Given this list of marker genes ST6GALNAC2 (NCBI Gene Id 6488), DLK1, MCUB, IGFBP4, GABRP, GNG2, DLK2, EOGT, PLXDC2, FRZB, CEP55 (centrosomal protein 55), ABCA13, PFKP, NAAA, STXBP6, FST (NCBI Gene Id 10468), GXYLT2, SOSTDC1, MTBP, GABRG3, NTN1, PRKAR2B, DUSP5, LRP4, HLA-DPB1, KCNMB4, KLK10, AEBP1, MCC, FGFR1, SHISA2, LTB, EYA2, CXCL2, ROBO2, MYB, SLIT3, COL5A1, DKK3, LAYN, DDX60 (NCBI Gene Id 55601), LHFPL2, NTRK2, CCL2, DAPL1, CAVIN1, KLF2, MT1E, SH3BP1, DGKA, CD40, ITGA9, FERMT1, STRA6, PHLDA1, CSTA (cystatin A), ISL1, ABCG1, PLPP2, ACTA2, TMEM158, GNG12, APOD, PRLR, RCBTB2, RELL2, PART1, STK38L, BCL2A1, SLC1A1, RAC2, CFH, NDE1 (nudE neurodevelopment protein 1), PMAIP1, LAMA4, EHF, VCAM1, ADM, TPM2, HTRA1, SYNPO2, HPRT1, LPL, COL1A2, NEIL3, RELL1, TNFAIP8, CFLAR, CPXM1, SH3BP5, COL16A1, NAP1L5, SELENOM, VCAN, RFLNB, TRAF3, ARSJ, SLC35F3, OSR1, UBD, LINC01315, NUDT11, FBXO32, TFAP2C, IFIH1, CA12, WNT10B, PAK3, TP63, IQCJ-SCHIP1, IFI16, OPTN, BOC, ST20-AS1, TNFAIP3, ZHX2 (zinc fingers and homeoboxes 2), SNAI2, DSCC1, OCA2, KCNAB3, SERTAD4, COL4A1, VWA2 (von Willebrand factor A domain containing 2), LAMP5, NPPC, GPX2, PLAU, ANGPT2, PGAP1, HSPA4L, LHFPL6, CCDC28B, RIC3, TYMP, EGR3, SLFN12, GAS6, PKP1, TTC39C, ACVR1B, PPP1R18, ACTG2, CCDC146, MEIS1, CXCR4, CX3CL1, COL7A1, STOX1, NEFH, PROM1, S100B, MAP1B, TRMT12, TGFA, STMN3, FBXO6, CCDC74A (NCBI Gene Id 90557), NBL1, IL27RA, SIRPA, SPARCL1, EVA1C, RGS10 (NCBI Gene Id 6001), RFLNA, ITGB4, ADCK1, HPDL, NPDC1, USP31, TMEM200A, SAA1, LSP1, ROPN1, SGK1, FAS, DST (dystonin), COL14A1, SLC6A8, MARCHF3, MX1, GCLC, ZNF565, PHLDA3, RARB, DCLK1, EMP3, NTRK3, STOM, SNCA, NUPR1, LGALS9, CSPG4, MMP16, RAB30, ADAMTS2, MEG3, LY75, MPPED2, CHST9, RBL1, KIAA1549L, CHST15, LAMA1 (NCBI Gene Id 3907), TNFRSF4, GYPC, FNBP1, KRT5, RAPGEF5 (Rap guanine nucleotide exchange factor 5), BIRC3, KLHL13, PDE4B, ITGB6, MIA, KCNN4, TRIM29, COL22A1, MAMDC2, TNS4, TRIM14, BDH1, CCDC3, NPL, ADAMTS18, FABP7, ABTB2, NGFR, SERPINE2, CXCL1, ST3GAL4, PTPRE, TM4SF1 (NCBI Gene Id 9004), TNFAIP2, IGFBP3, KRT15, TICAM1, NFE2L3, SLC16A1, SLCO3A1, PTX3, ANO1, HS3ST1, ETV4, CYTH1, MYC, ELAPOR1, PPP1R14A, UACA (NCBI Gene Id 55075), TSLP, KRT23, FRMD4A, MARK1, PTGER4, EFHD1, GINS3, GFRA1, TSHZ2, CLDN10, SMOC2, LEF1, REEP2, AK4, BCL2, SFN, SULF1, CXCL3, TSPAN2, LGALS1, CD70, IL32, SEPTIN4, PSTPIP2, PALLD, DDIAS, IL17RD, ZNF490, PITX1, TIAM1, KITLG, PAPSS2, C17orf49, CDKN1A, NCALD, PRNP, PTK2B, MCAM, KRT14, FAM216A, PMP22, KREMEN2, CD82, SCD, MGP, TRNP1, QPCT, EDAR, SOX10, CLDN1, SRGAP3, IFITM1, FXYD5, FEZ1, CNFN, TFAP2A, TRPV4, LUZP1, PDZRN3, NLRP1, ITM2A, HLA-B, SPRY4, NRP2, LPAR6, FBLN2, UBAC1, NEDD4, FGF3, HEY1, FHL2, CRYBG1, PAQR4, ACP5, CIMAP1B, BHLHE40, RASSF6, PADI2, TCEAL2, MFAP4, SOX15, RND1, PLAT, TNFRSF14, CD200, FOXC1, DMRTA2, COL9A1, KIAA0825, LINC01503, SIX1, MOXD1, DLL3, KNL1, SSPN, TNFSF10, CYP4X1, MARVELD1, NAMPT-AS1, NID1, WNT10A, ROBO1, GPM6B, SPHK1, GLCE, ISLR, C6orf141, CCDC122, SEMA6A, ITPR2, NFATC1, S100A2, NRTN, LSAMP, MAP2, SEZ6L2, PAX9, SEMA6D, NPB, C1QTNF1, CDKAL1, SCARB1, THY1, LPGAT1, VSIR, SFRP1, FZD7, CCL20, LGR6, SPEG, FMNL3, RASIP1, TUBB6 (tubulin beta 6 class V), here is a description of the gene set: studied in species Homo sapiens Human Gene Set: HE_LIM_SUN_FETAL_LUNG_C1_SMG_BASAL_CELL from publication He P, Lim K, Sun D, Pett JP, Jeng Q, Polanski K, Dong Z, Bolt L, Richardson L, Mamanova L, Dabrowska M, Wilbrey-Clark A, Madissoon E, Tuong ZK, Dann E, Suo C, Goh I, Yoshida M, Nikolić MZ, Janes SM, He X, Barker RA, Teichmann SA, Marioni JC, Meyer KB, Rawlins EL (PMID 36493756) SMG basal